Given this list of marker genes Shroom1, Actn3, Myh8, Xirp2, Slc6a4, Sipa1l1, Fscn1, Coro2b, Lasp1, Myh7b, Ablim2, Myo5a, Afdn, Tagln3, Kbtbd13, Panx1, Vps16, Myo1d, Vinac1, Pknox2, Cd2ap, Add1, Tpm1, Hip1 (huntingtin interacting protein 1), Arpc3, Myh11, Ajuba, Cotl1, Ctnna3, Fmnl3, Tln1, Itprid2 (NCBI Gene Id 70599), Actr3, Tpm3, Coro2a, Ablim1, Marcksl1, Eps8l1, Tpm3-rs7, Pls1, Myh10 (NCBI Gene Id 77579), Hip1r, Myo9a, Myo7a, Ctnnal1, Cnn3, Shtn1, Cyfip1, Xirp1, Actn2, Myo18a, Tln2, Add2, Sptbn4, Iqgap2, Capza1b, Anxa8, Arpc1b, Sptan1, Mtss1, Ttn, Arpc1a, Arpc4, Myl4, Myo9b, Actn1, Myo1g, Coro6, Gas2, Twf2, Limd2, Plec, Vcl, Flna, Gjb6 (NCBI Gene Id 52881), Myo1e, Trpv4 (NCBI Gene Id 80591), Fscn3, Capg, Scin, Marcks, Arpc2, Myo1b, Fhod3, Capzb, Avil, Gsn, Macf1, Myo1c, Neb (nebulin), Syne3, Lima1, Lrpprc, Myo3a, Aif1l, Tpm4, Myo18b, Myo1a, Actr2, Flnc, Flnb, Ezr, Tnni3, Tmem201, Dmtn, Myh9, Samd14, Nebl, Myo5b, Tpm2, Fmnl2, Sptb, Lcp1, Myh7, Cdk5r1, Coro1b, Espn, Luzp1, Cnn1, Cnn2, Dbn1, Iqgap3, Micall2, Arpc5l, Flii, Map1s, Myo19, Myh15, Hcls1, Antxr1, Eps8l2, Phpt1, Adss1, Ppp1r9a, Amotl2, Myo15a, Fgd4, Dstn, Nexn, Tulp1, Gas2l1, Pick1, Cttn, Myh6, Actr3b, Egfr, Add3, Sptbn2, Tnnc1 (NCBI Gene Id 21924), Twf1, Myh13, Klhl17, Coro1c, Gas2l2, Vill (villin-like), Myh14 (myosin, heavy polypeptide 14), Myh3, Nrap, Actn4, Iqgap1, Espnl, Myh4, Abl1, Triobp, Fermt2, Myh2, Fermt1, Myo5c, Cfl1, Gas2l3, Abi3bp, Shroom2, Ppp1r9b, Coro1a, Misp, Abitram (NCBI Gene Id 230234), Wdr1, Camsap3, Myh1, Fmnl1, Ablim3, Cfl2 (NCBI Gene Id 12632), Ctnna1, Syne1, Kptn, Myo6, Myo7b, Spta1, Abi3, Pof1b, Bloc1s6, Shroom4, Clasp2, Capza3, Ctnna2, Frg1 (FSHD region gene 1), Capza2, Mprip, Tagln2, Vil1, Ermn, Myo16, Pls3, Fhod1, Myo1h, Sptbn5, Gas7, Myo10, Dbnl, Bin1, Fscn2, Sptbn1, Myo1f, Cacnb2, Shroom3, Arpc5, Eef2, Svil, Rcsd1, Aif1, Capza1, Clmn, here is a description of the gene set: Binding to an actin filament, also known as F-actin, a helical filamentous polymer of globular G-actin subunits. Mouse Gene Set: GOMF_ACTIN_FILAMENT_BINDING studied in species Mus musculus